The following is a description of a gene set: Any process that stops, prevents or reduces the frequency, rate or extent of mitotic cell cycle phase transition. species: Mus musculus Mouse Gene Set: GOBP_NEGATIVE_REGULATION_OF_MITOTIC_CELL_CYCLE_PHASE_TRANSITION, and this is the list of marker genes: Dync1li1, Inhba, Rgcc, Fhl1 (NCBI Gene Id 14199), Ppp2r3d, Ctdsp1, Trim39, Rbbp8, Plk1, Myo16, Taok3, Cdc6, Nae1, Haspin, Bcl2, Brcc3dc, Pkd2, Gpr132, Rfwd3, Foxn3, Arhgap33os, Rbl1, Brd7, Miip, Blm, Stk35, Mir26a-1, Zfp830, Trex1, Cacnb4 (NCBI Gene Id 73120), Mad2l1bp, Atr, Cdc73, Ndc80, Nabp1, Cdk5rap3, Mir26a-2, Nbn, Brsk1, Mir26b, Ska1, Foxo4, Rad50, Babam2, Zfp655, Cenpe, Fbxo5, Birc5, Rpa2, Uimc1, Ccng1, Plk3, D7Ertd443e, Ska3, Rad21, Nabp2, Rb1, Zw10, Kank2, Aven, Creb3l1, Klf4, Usp44, Topbp1, Ezh2, Ik, Bard1, Inip, Tpr, Donson, Mad1l1, Bub1, Wac, Dlg1, Fam107a, Hus1b, Prpf4b, Ptprv, Vps4a, Wee1, Chek1, Trip13, Rint1, E2f7, Pabir1, Ier3, Pcid2, Ccnd1, Etaa1, Prap1, Klhl22, Gigyf2, Zfp36l2, Dact1, Bub1b, Acvr1, Chfr, Nuf2, Cep192, Tpra1, Cdkn2b, Gen1, Orc1, Cdk1, Pten, Chmp4c, Pkmyt1, Ctdsp2, Zfp207, Ccl12, Ticrr, Ccnb1-ps, Mrnip, Ccnb1, Zfp36l1, Taok2, Brcc3, Slfn1, Pdik1l, Prmt2, Pinx1, Cdkn1a, Trp53, Zfyve19, Ctdspl, Nop53, Gpnmb, Mbd4, Fzr1, Dusp1, Sde2, Anapc15, Bub3, Zwint, Anapc15-ps, Mbtps1, Knl1, Aurkb, Mad2l1, Clspn, Dtl, Btn2a2, Abraxas1, Dgkz (NCBI Gene Id 352984), Fbxo7, Khdc3, Spc24, Jade1, Rbl2, Mbtps2, Cdk2ap2, Syf2, Cdc14b, Cdca8, Gjc2, Xrcc3, Atm, Prkdc, Babam1, Lcmt1, Usp47, Cdc20, Zc3h12d, Ints3, Taok1, Cdk5rap2, Rad17, Tex14, Brca1, Apc, Mre11a, Dcun1d3, Hus1, Ttk (Ttk protein kinase), Spdl1, Kntc1, Fbxo31, Psmg2, Crlf3, Zwilch, Spc25, Rps27l, Incenp